The following is a description of a gene set: This event has been computationally inferred from an event that has been demonstrated in another species.<p>The inference is based on the homology mapping from PANTHER. Briefly, reactions for which all involved PhysicalEntities (in input, output and catalyst) have a mapped orthologue/paralogue (for complexes at least 75% of components must have a mapping) are inferred to the other species. Reactome Pathway: Signaling by TGF-beta Receptor Complex part of: Signaling by TGFB family members electronically inferred by orthology from the curated human pathway species: Mus musculus, and this is the list of marker genes: Fkbp1a, Tfdp1, Rnf111, Smurf2, Ube2d1, Mapk3, Itgb5, Itgb8, Snw1, Tgfb1, Rps27a, Atp1b4, Ltbp3, Nedd8, Cdk8, Tgif1, Pard3, Ltbp2, Ncor2, Smad3, Wwtr1, Smurf1, Bambi, Smad7, Mtmr4, Cbl, Ubb, Men1